The following is a description of a gene set: Human Gene Set: GOBP_POSITIVE_REGULATION_OF_INTRACELLULAR_LIPID_TRANSPORT Any process that activates or increases the frequency, rate or extent of the directed movement of lipids within cells. studied in species Homo sapiens, and this is the list of marker genes: LDLRAP1, SCP2, ABCA12, ANXA2P2, ANXA2